The following is a description of a gene set: studied in species Mus musculus Mouse Gene Set: MIR_323_5P Genes predicted to be targets of miRBase v22 microRNA mmu_miR_323_5p in miRDB v6.0 with MirTarget v4 prediction scores > 80 (high confidence targets). from publication Chen Y, Wang X (PMID 31504780), and this is the list of marker genes: Tet2, Dhx15, Elfn2, Gnal, Tnip2, Morc4, Prokr1, Xkr6, Pnkd, Adgra1, Eno1, Mylk2, Ube2q2l, Traf4 (NCBI Gene Id 320278), Glycam1, A130010J15Rik, Anxa10, Nup160, Ralb, Gnpnat1, Gm11437, Atxn7l1, Peg10, Slco3a1, Tssk2, Ubqlnl, Mr1, Gtpbp1, Stard8, Mettl8, Kcnma1, Smco3, Gria1, Amd1, Clptm1, Ddb1, Alg12, Stim1, Eno2, Nkx2-1, BC107364, Rad51b, Sftpb, Tbc1d24, Slc2a12, Sh2d5, Slc35e2, Rufy2, Xkr5, Ube2m, Sdhd, Iqsec2, Cxxc4, Mixl1, Mxd4, Pcsk5, Col5a2, 9330159F19Rik, Spen, Il33